The following is a description of a gene set: Genes predicted to be targets of miRBase v22 microRNA hsa-miR-660-5p in miRDB v6.0 with MirTarget v4 prediction scores > 80 (high confidence targets). from publication Chen Y, Wang X (PMID 31504780) studied in species Homo sapiens Human Gene Set: MIR660_5P, and this is the list of marker genes: JPH1, SFXN2, WDR36, NUFIP1, ARMCX3, NRCAM, VDAC1, NPAS3, NBEA, ALPK1, MED8, KPNA4, DNAJC3, LEPR, OR12D3, SMOC1, GPATCH2L, ARHGAP36, MDM2, RRAGC, FUT10, SIM1, SLC46A3, AGPAT5, LPCAT2, KIF3A, MCPH1, TPD52L2, RHOH, NR3C1, TFCP2, CDR2L, ELAPOR2, ZNF326, MYH15, LIMCH1, STX16, LRIG2, ANAPC5 (NCBI Gene Id 51433), UGCG, TMED7-TICAM2, TRAF6, EPAS1, OBI1, CDH13, IRS1, RBBP6, LMNTD1 (lamin tail domain containing 1), ZBTB34, CCDC126, CLEC3A, ZNF805, RMDN1, KBTBD8 (NCBI Gene Id 84541), PCDH9, STMP1, PPP6R3, SPCS2, UPB1, VPS13B, SLC10A7, FOLH1B, COG6, UNC79, DCAF12, TMEM70, HIPK1, ACTRT3, LAMC2, CD8A, CENPM, CYP4V2, TMEM64